Given this list of marker genes ABCB1, QDPR, FOSB, SGCE, PPP1R15A, STAB1, AGTR1, HCLS1, INHA, DLX4, RNASE1, CYB5A, SC5D, TM7SF2, ABCC3, PTS, WWTR1, SLIT2, PAPSS2, ADIPOR2, TLE1 (TLE family member 1, transcriptional corepressor), MERTK, VSNL1, AOX1, CXCR4, MAOA, ITGA7, CLEC3B, PON2, GPC3, SORD, SPTBN1 (NCBI Gene Id 91654), PDE4C, DNM2, DCAF8, CPE, APRT, NR2F1, COL6A1, ADH1B, LPL, SRRM2, DLK1, CHGA, IFIT1, LUM, TNXB, MXRA5, PCBD1, NCAM1, C1QB, KCND3, HAGH, IGF2, VCAN, MEF2C, AKR1C1 (NCBI Gene Id 9418), PEG10, PTP4A1, HLA-DMA, ZNF451 (zinc finger protein 451), AANAT, SCP2, KLHDC3, NUPR1, APOC1, CD14, LRRC32, PLK3, FUCA1, PHYH, ALDH3A2, CHGB, ZBTB16, AHDC1, RBPMS, NR1D1, KRT4, PTPN12, GRB10, FADS1 (NCBI Gene Id 3992), TPM2, ALAS1, ALDH1A1, RIDA, NECAB3, ELAC2, ENPP2, EFNA2, DDIT4, SEC11A, TFAP2B, GMPR, AGL, FOXO4 (forkhead box O4), GJA1, SH3BGR, TMX4, LDOC1, CFD, PLIN2, NHERF1, GBE1, ITPR2, ST3GAL5, TGFBR2, MBNL1, ALOX15, ZIC2, RHOB, EPB41L3, RGN, IGFBP6, CRYZ, RGS2, TCF7, QPCT (NCBI Gene Id 25797), EPHX1, TRIB2, HSPG2 (heparan sulfate proteoglycan 2), CADM1, MYH11, NR5A1, ACO1, NFE2L2, MRC1, TBC1D2B, SNCG, ALDH6A1, FSTL3, CDK5R1, MAPRE2, NECTIN2, FSTL1, CLN3, AOC3, SRPX, TIMP3, CNN3, ABLIM1, IQGAP1, CITED2, EEF1A2, IFI27, COL4A1, PDGFRA, PENK, APOD, TST, CCL2, LAMB2, GET1, KDM5D, ENG, CCND2, CDKN1C, AKAP17A, DDX3Y, SEPTIN4, GNG12, CBX6, IGFBP4, IL1R1, COL15A1, ALDH7A1, SCG2, C1S, HPGD, RAB5C, RHOD, GOLGA8A, AADAC, SLC23A2, DHRS1, DYNLT3, COL1A2, ADH1A, NR4A1, FBXL7, ZBTB20, COX7A1, GSTM1, COBLL1, C7, TGFBR3, RARRES2, PDE2A, MCFD2, FADS2, VSIG4, FABP4, NQO1, HOXA5, NDN, CCND1, CDKN2C, MSMO1, AHCYL1, COL6A2, BIRC2, TNFAIP2, PDGFRB, CRYAB, PSMC2, MAOB, GAGE12F, WDR7, VEGFA, DLG5, SCO2, TUSC3, FCGRT, FKBP5, LDLR, NFKBIL1, CALB2, IRF9, TSPAN3, MAP2K3, TPM1, IGHG3, IQGAP2, PBX1, ITPR1, HSPB2, ID2B, ST6GALNAC4, PLIN1, MTUS1, TGM2, MTSS1, PHYHIP, HYI, GPD1L, HSD17B4, CD163, NME3, ABCD3, BIN1, NRTN, TSPAN7, PLCG2, PEG3, FEV, RAB31, EGFR, AGPAT2, MYL9, EPOR, GSTT1, PRPF19, VTN, SLC26A2, ST3GAL4, TTLL12, ITGB5, FOS, TCEAL4, GSTA4, CD34, DAB2, JADE2, ATP4A, SOD3, PTH1R, EPAS1, RBP1, PCOLCE, CDC42EP1, GPX3, MAN2A1, HLF, GLRX, ECM2, RIMS2, RGS5, NPTX2, G0S2, ECHS1, TSPYL2, ROR2, GADD45G, CCN3 (NCBI Gene Id 4856), SELENOP, CHRNB1, SORBS2, CCL15, LSP1, TNFRSF10B, BCL6, RSRP1, JUNB, CDH2, FOSL2, TMEM97, BAMBI, APOE, RAB11A, PER1, DENND2B, RAB13, EMP3, CD55, SLC4A3, PRB4, SGK1, GSTA2, LTBR, SERPINA5, DDR2, SLC29A1, PCCA, ACOT2, SERPINH1, here is a description of the gene set: Human Gene Set: MODULE_19 Adrenal gland - metabolic genes. studied in species Homo sapiens